The following is a description of a gene set: Mouse Gene Set: MIR_298_5P Genes predicted to be targets of miRBase v22 microRNA mmu_miR_298_5p in miRDB v6.0 with MirTarget v4 prediction scores > 80 (high confidence targets). from publication Chen Y, Wang X (PMID 31504780) species: Mus musculus, and this is the list of marker genes: Kctd10, Kcnab2, Senp5, Grin3a, Tac4, Erbb4, Adss2, Ltk, Elovl6, Atrx, Tmem25, Abhd2, Spryd7, Arl8b, Gtpbp2, Igf1r, Tkfc, Rab11b, Onecut2, Sdhd, Luzp1, Tmem121b, Cntn4, Gata4, Myo1d, Eeig1, Nectin3, Gm266, Csnk2b, Capn5, Ncs1 (NCBI Gene Id 99076), Ehd1, Hrh3, Gm11992, Kdm4b (NCBI Gene Id 224900), Gpatch8, Ndst3, Rbmxl2, D430041D05Rik, Ark2n, Smyd3, Pnkd, Prkn, Mettl6, Tinf2, Rspo4, Jrk, Cpeb4, Nek6, A430033K04Rik, Gabbr2, Lsm11, S100pbp, Scara3 (scavenger receptor class A, member 3), B3galt1, Mmp17, Kdm7a, Map1lc3a, Fkbp1a, Abcb7, Ttyh2, Mapkbp1, Tomm22, Kpna6, Gabra1, Rtl6, Osbpl7, Ces2g, Cenpb, Nfix, Rgs9bp, Lelp1, Rufy3, Ar, Tnpo1, Nemp1, Nalf1, Rnf144b, Chtf8, Wdr27, Kansl1, Kdm2a, Gbf1, Mlxip, Col5a2, Mmp16, Klf12, Nrbp1, Zfr, Brms1l, Smarcc2, Zfp827, Epcip (exosomal polycystin 1 interacting protein), Shisa6, Ahdc1, Rubcn, Zdhhc3, Tbx20, Mmd, Npas3, Pcdh15, Gspt2 (G1 to S phase transition 2), Hnrnpk, Atp2a2, Dync1li1, Tmem127, Msrb3, Pfkfb4, Chac1, 2310022A10Rik, Arhgdia, Atcay, Tango6, Abcc9, Trim41, Camta1, Celsr1, Abcg4, Tef, Pan2, 1600012H06Rik, Rhbdl3, Frmd8, Scn2b, Kcna2, Kcnb1 (potassium voltage gated channel, Shab-related subfamily, member 1), Cd209b, Mboat7, Etf1, Cybrd1, Ppy, Morf4l2, Plppr4, Pak4, Rcan2, Dmtn, Marcks, Gm11437, Tet1 (tet methylcytosine dioxygenase 1), Ubap1, Khdrbs1, Pcsk7, Gm7694, Twist1, Pcp4, Hey2